Given this list of marker genes CXCL2, IL10RB, TNFRSF1B, IL1R1, IL1R2, CCL20, IL1B, CCL3, CSF1, CCL2, IL10, TNFRSF1A, IL1A, TIMP1, FPR1, CSF2, IL12A, CCR5, IL10RA, CXCL1, TYK2, ICAM1 (intercellular adhesion molecule 1), CSF3, IL6, CCR2, FCER2, CXCL10, TNF, IL1RN, LIF, CD86, IL12B, IL18, CD80, JAK1, PTAFR, CXCL8, CCL22 (C-C motif chemokine ligand 22), CCL5 (C-C motif chemokine ligand 5), CCR1, STAT3 (signal transducer and activator of transcription 3), CCL3L3, CCL4, CCL19 (C-C motif chemokine ligand 19), PTGS2, here is a description of the gene set: Interleukin-10 signaling species: Homo sapiens Human Gene Set: REACTOME_INTERLEUKIN_10_SIGNALING